Given this list of marker genes Map3k7, Pgr, Meaf6, Prm1 (protamine 1), Trim66, Smarcd1, Nanog, H3f4, Kdm4a, Taf6 (NCBI Gene Id 21343), H3c1, H3c13, Ino80, Maged1 (NCBI Gene Id 94275), Zfp618, Chek1, Tspyl3, Cenpa, Nfatc2, Pou4f1, Rcor2, Arid2, Top2b, Jak2, Tada2b, H2ac15, Tal1, Pds5b, Exosc4, Atf2, Ankrd2, Nsmf, Smarcb1, Flywch1, H3c8, Jarid2, L3mbtl1, Rad21, Pitx3, H2al1m (NCBI Gene Id 76383), Foxh1, Park7, Zfp57, H1f1, Ankrd31, Tbx22, Hnrnpl, Noc2l, Taf5, Ppp1r10, Pole4, Rhox5, Dppa3, Irf1, Prmt5, Ezh2, Plk2, Msl1, Zfp42, Mga, Parp1, Brd8, H2bc12, Tspyl4, H2ac4, Ncapd3, Jade1, Mael, Nucks1, Fam111a, Kdm4c, H1f3, Ncoa3, Nasp, Mta3, Smarcd2, H2aj, Mybbp1a, Fancc, Atxn7, Pou1f1, Ubr5, Macroh2a2, Ppp4c, Kdm5c, Ar, Fancm, Gata5, Eme1, H2bc21, 0610010K14Rik, Znhit1, Hmgn3, Chmp7, H3c15, Pola1, Chmp2a, Crx, Irf3, Myc, Daxx, Yy1, Asf1a, Lhx3, H2bc9, Chd7, Smad1, Trim33, Esco1, Cenpb, Kmt2e, Nr3c2, Rarg, Hmgb2, Rara, Sirt7, Nap1l1, Taf1, Gata4, Ercc6, Fancf, Hdac3, Brpf1, Kdm4d, Zfp827, Rnf2 (ring finger protein 2), Taf4, Mad2l2, Kdm5a, Pcna, Vps72, Gabpa, Usp3 (ubiquitin specific peptidase 3), Loxl2 (lysyl oxidase-like 2), Taf7, Nr4a2, Tbx2, Med1, Srpk2, Smad4, Myo1c, Dr1, Taf10, Phc1, Tox4, Pias2, Pbrm1, Banf1, Ssrp1, Phf10, Csnk2b, Skic8, Zmiz1, H2bc18, Tbx21, Kansl1l, Rbl2, Hmga2, Sinhcaf, Mbip, Hif3a, Bmyc, Cebpb (NCBI Gene Id 18031), Ncor2, Ist1 (NCBI Gene Id 71955), Hsf4, Jade2, Phox2a, Rfx3, Vrk1, Cdk2ap2, Yeats4, Pias4, H2az1, Stag1, Kansl2, Nr3c1, H4c14, Atxn7l3, Tbx19, Luzp1, Tbx4, Ebf4, Pbxip1, Nfkb1, Tcf3, Yeats2, Eny2, Sap30l, Zfp385a, Nfe2l2, Fancb, Runx1, H4c3, Kdm5d, Nhlh2, Smarca5, Mta1, Tonsl, Pias3 (NCBI Gene Id 54605), Rbbp4, Jun, Arid4a, Nmnat1, Trp63, H2al1k, H2ac21, Wdr5, Setd3, Trim28, Macroh2a1, Smarcc2, Ruvbl2, Nr6a1, Rif1, Phf20l1, Ing3, Polr2a, Kat5, Zzz3, Srpk1, Gm10257, Csnk2a1, Ep300, H2ac10 (H2A clustered histone 10), Kat7, Spin1, Hic1, Rad50, Shprh, Ash2l, H2ac23, Taf12, Zmynd8, Eed, Bud31, Taf5l, Rrp8, Rrp1b, Baz1b, Npm2, Sumo1, Camta2, Exosc5, Phf12, H2ac20, Zeb2, Phox2b, Ino80d, Phf14, Ran, H1f2, Rnf20, Ppard, Tspyl1, Nfatc1, Irf4, Zmiz2, Sf3b3, Kat2b (K(lysine) acetyltransferase 2B), Htra2 (NCBI Gene Id 64704), Nsd1, Fer, Orc2, Morf4l2, Ice1, Gon4l, Dnmt3a, H2ac1, Kdm3a, Wdr43, Fbh1 (F-box DNA helicase 1), Creb3l2, Pole3, Arid1a, Msh6, Pds5a, Ing2, Cdk4, Tspyl5, Clock, Hat1, Tnks1bp1, H2al1n, Nsd2, Lemd2, H3c14, Tet1, Tbx15, Eomes, Actr5, Suz12, Bnc2 (NCBI Gene Id 71498), Arid1b, Mcm2 (NCBI Gene Id 17216), Mecp2, Sphk2, Tbx10, Uhrf2, Hmga1, Tbr1 (NCBI Gene Id 21375), Kat8, Aldoa, Hif1a, Lrwd1, Morf4l1, Zfa-ps, Esrra, H2ac25, Chd4 (NCBI Gene Id 77403), Hcfc1, Casz1, Mbd1, Igfbp3, Rest, Actr8, Pcgf2, H2ac13, Nedd4, Mixl1, H4c17, Ipo4, H2bc1, Sox2 (NCBI Gene Id 20674), Arrb1, Dffb, Nufip1, Tnp2, Kat6b, Ell, H2al1f, Tcf7l2, Vdr, Baz2b, Brms1, Trps1, Plk1, Hand2os1, Pou5f1, Esr1, Chaf1b, Kmt5a, Bmi1, Hdac2, Ep400, Stat1, Ppp4r3b, Rbl1, Klf2, Cbx8, Mms22l, Sgf29, Kmt5c, Ldb1, Mphosph8, Fanca, Esco2, Smc3, Tada2a, Kdm1b, E2f4, Chd1 (NCBI Gene Id 75119), Tbp, Timeless, H2bc27, Hnf4a, Smarca4, Hmgn1, Mre11a, Hnrnpa2b1, H2bl1, H2ab3, H4c1, Tcf7, Ing1, Hmgn2, Rbmxl1, Lef1, Tbx20, Hdac1, Cfdp1, Cenpc1, Cited2, H1f0, Rad51ap1, Tbx5, 4930480E11Rik, Upf1, Dntt, Fam47c, Ikzf1, Fiz1, Ube2b, Fance, Dnmt3l, Isl1, Smarcad1, Sdr16c5, H4c16 (H4 histone 16), Msl3l2, Rb1, Msl2, A1cf, Bend2, Mrgbp, Rsf1, Thap7, H2al3, Exosc3, Cdk2ap1, H3f3b, H2ac24, Hnrnpk, Dffa, Nr1d1, Hnrnpdl, Srsf2, Tcf7l1, Ctr9, Cops9, Rbbp7, Dmap1, Stag3, Mau2, H3c4 (NCBI Gene Id 319149), Gata3, H2ac11, Actbl2, Morc2a, Mcrs1, Satb2, Chd6, Ddx23, Basp1, Sirt1, Stag2, Sox18, H2ap, Hmgxb4, Cbx2, Spin4, Hells, Chd2, Tada3, Oip5, Actl6b, Faap100, Ascl5, Hlcs, Kdm5b, H4c18, Bicra, Nop53, Ctnnb1, Morc3, Mef2a, Nfrkb, Mta2, Chd3, Prdx1, H3f3c, Esr2, Cbx6, Smc2, Dpf3, H2ac7, Brd3, Setd1a, Kdm2a, H1f9, Arid4b, Cenps, Relb, Chd8, Rad18, H3c11, H2al1a, Brd1, Suv39h1, H4c12, H3c2, Smarcc1, H4c6, Myod1, Rbmx, Fancl, Sap130, Atrx, Alkbh1, Cdca5, Taf2, H2ac19 (NCBI Gene Id 319192), Slf1, Hp1bp3, Zc3h8, Sirt6, Plcb1, Egr1 (early growth response 1), Foxc1, Parg, Kat14, Bcl7b, Prdm9, Trp53, Zbtb46, Snai1, Dnmt3b, Tcp1, Rpa2, Spi1, Actb, Scml2, Dpf2, Prkaa1, Exosc10, Ahctf1, Prkdc, Ppargc1a, Ddx6 (NCBI Gene Id 78705), Capn2, Smarce1, H2az2, Sp1, H3c7, Baz1a, Pawr, Cbx1, Ice2, Usp22, H1f5, Rhno1, Ddx11, Uxt, Acte1, H1f8, Obi1, H2ac22, Epc1, Klhdc3 (NCBI Gene Id 71765), Aff4, Enc1 (ectodermal-neural cortex 1), Ing5, Mtbp, Sfpq, Brd8dc (BRD8 domain containing), Sall1, Akap8, Kansl3, H2ab2, Glyr1, Setd5, Ing4, H3c3, Kif22, Brpf3, Dscc1, Taf9b, Tgm2, Kdm3b, Hand2, Pramel13, Klf1, Tbx1, Mlxipl, Hdac5, Srf, Uba1, Gatad2a, Mexis, Bicral, Tfpt, Shld1, Stat3, Nap1l3, Supt7l, H2ac6, Shld3, Ankrd17, Faap24, Ino80b, Fam47e, Cbx3, Nacc2, Ncor1, Vrtn, Ino80e, Psip1, Nr4a1, Morc2b, Pou4f2, Pogz, Bcl11a, Mbd4, Bcl7a, Cops5, Muc1, H2bc14 (H2B clustered histone 14), Brms1l, Csnk2a2 (NCBI Gene Id 97446), Hes1, Ube2a, H4c2, H3f3a-ps1, H2al1j, Wdr76, Incenp (inner centromere protein), H2ac12, Dlx5, Bend3, Max, H1f4, Ehmt1, Dek, H1f7, Actg1 (NCBI Gene Id 230535), Zfx, Sf3b1, H4c4, Nipbl, Bcl7c, Ccnd2, H2ax, Tcf23, Wbp2, H2al1e, Msl3, Ccar2, Snw1, Etv3, Runx3, Wdr82, Supt16, Rela, Taf6l, Hmgn5, Ino80c, Ehmt2, Id2, Cbx5, Sin3a, Ss18l1, Brd2, Tcf12, H3c6, Cdk2ap1rt, Nrip1, Tcf4, Ark2n, Cecr2, Calcoco1, E2f1, Ankrd11, Klf4, Mxd1, Rnf40, Usf1, Asf1b, Bcl11b, Trp73, Hdac4, Tbx18, Runx2, H3f5 (H3.5 histone), Phc2, Ncoa1, Kdm4b, Tbx3, Swi5, Tardbp, Prm3, Actl6a, Sfr1, H2bc26, Sirt2, Tipin, Fancg (Fanconi anemia, complementation group G), Atp1b4 (NCBI Gene Id 67821), Nap1l2, Kat6a, Esrrb, H4c9, Set, Uchl5, Skic3, Pelp1, Xrcc1, Mbd2, Hnrnpab, Pax6, Trrap, Snai2, Plk3, Stat6, Gatad2b, H3c10, Faap20, Dhx9 (NCBI Gene Id 98320), Rbm31y, H2al2b, Nelfe, Yy2, Tmpo, Padi2, H2bc22, Pias1, Mbtd1, Mnx1, Ppp4r2, Supt20, 4930402K13Rik, H2al1o, Hnf1a, Smarca1, Prdm10, Jmjd1c, Uhrf1, Rcc1, Brd4, H2bc3, Smad2, Gm6421, Tada1, Akap8l, H2ac8, Chaf1a, Foxd3, Nr1h3, Dnmt1, 1700013H16Rik, Fank1, Tasor, H2al2a, Cpsf6, Taf9, Irf7, Chrac1, Ezh1, Slf2, Sox10, Hsf1 (heat shock factor 1), Ogt, Suv39h2, Crebbp (NCBI Gene Id 547230), T, Rad51, Ruvbl1, Wapl, Ddx21, Men1 (NCBI Gene Id 17283), H2bw2, Hpf1, Myocd, Smad3, Smcr8, Smarcd3, Hnrnpd, Rxra, Kdm1a, Hmga1b, Shld2, Parpbp, Sf3b5 (NCBI Gene Id 66125), Nr0b2, H2al1b, Brd9, Anp32e, H4c8, Creb3l1, Tbx6, Creb1, Nr1h4, Suds3 (NCBI Gene Id 71954), Chaserr, Trim24, Brd7, Pink1, Zfp143, H2ab1, Hr, Mbd3, Smarca2, Prm2, Ss18, Orc5, Esrrg, Dpf1, Cdkn2a, Cbx7, Srcap, Ilk, Hira, Nsd3, Mis18a, Cenpx, Baz2a, Sall4, Sprtn, Ring1, Kansl1, Anapc7, Nap1l4, Orc3, Tnp1, Sap30, Chd5, Epc2, Tspyl2 (NCBI Gene Id 77013), Akirin2, Jade3, Slx4, Trnp1, Satb1, Akirin1, H1f6, Dvl3, Kat2a, Actr6, Bptf, Aptx, H4c11, Phf20, Brdt, Bcas3, Sin3b, H3f3a, Ubr2, Supt3, here is a description of the gene set: Mouse Gene Set: GOCC_CHROMATIN The ordered and organized complex of DNA, protein, and sometimes RNA, that forms the chromosome. species: Mus musculus